Given this list of marker genes CD44, SNAI2, HMGA2, BCAT1, NOLC1, CALD1, here is a description of the gene set: BACKGROUND: We previously identified DnaJ-like heat shock protein (HLJ1) as a gene associated with tumor invasion. Here, we investigated the clinical significance of HLJ1 expression in non-small-cell lung cancer (NSCLC) patients and its role in cancer progression. METHODS: We induced HLJ1 overexpression or knockdown in human lung adenocarcinoma CL1-5 cells and analyzed cell proliferation, anchorage-independent growth, in vivo tumorigenesis, cell motility, invasion, and cell cycle progression. Expression of genes that act downstream of HLJ1 was examined by DNA microarray analysis, pathway analysis, and western blotting. We measured HLJ1 expression in tumors and adjacent normal tissues of 71 NSCLC patients by quantitative reverse transcription-polymerase chain reaction. Associations between HLJ1 expression and disease-free and overall survival were determined using the log-rank test and multivariable Cox proportional hazards regression analysis. Validation was performed in an independent cohort of 56 NSCLC patients. Loss of heterozygosity (LOH) mapping of the HLJ1 locus was analyzed in 48 paired microdissected NSCLC tumors. All statistical tests were two-sided. RESULTS: HLJ1 expression inhibited lung cancer cell proliferation, anchorage-independent growth, tumorigenesis, cell motility, and invasion, and slowed cell cycle progression through a novel STAT1/P21(WAF1) pathway that is independent of P53 and interferon. HLJ1 expression was lower in tumors than in adjacent normal tissue in 55 of 71 patients studied. NSCLC patients with high HLJI expressing tumors had reduced cancer recurrence (hazard ratio = 0.47; 95% confidence interval = 0.23 to 0.93; P =.03) and longer overall survival (HR = 0.38; 95% CI = 0.16 to 0.89; P =.03) than those with low-expressing tumors. Validation in the independent patient cohort confirmed the association between HLJ1 expression and patient outcome. LOH mapping revealed high frequencies (66.7% and 70.8%) of allelic loss and microsatellite instability (87.5% and 95.2%) of the HLJ1 locus at chromosome 1p31.1. CONCLUSIONS: HLJ1 is a novel tumor suppressor in NSCLC, and high HLJ1 expression is associated with reduced cancer recurrence and prolonged survival of NSCLC patients. from publication Tsai MF, Wang CC, Chang GC, Chen CY, Chen HY, Cheng CL, Yang YP, Wu CY, Shih FY, Liu CC, Lin HP, Jou YS, Lin SC, Lin CW, Chen WJ, Chan WK, Chen JJ, Yang PC (PMID 16788156) Genes down-regulated in CL1-5 cells (lung cancer) overexpressing DNAJB4 off a plasmid vector. species: Homo sapiens Human Gene Set: TSAI_DNAJB4_TARGETS_DN